Given this list of marker genes Ank3, Bok, Parp1, Cnga2, Trpm4, Chrna1, Rbfox2, Scn8a, Nedd4l, Ppif, Park7, Myoc, Scn1b, Scn2b, Smad7, Slc6a4, Atp5if1, Ywhah, Gja1, Ptpn3, Chrna5, Kcnh2, Chrne, Scn5a (NCBI Gene Id 20271), Rack1, Ntsr1, Chrna6, Gclc, Gclm, Chrna4, Scn2a, Scn1a (NCBI Gene Id 227987), Best2, Cacna1d, Chrnb4, Cacna1i, Hcn2, Jun, Kmt2a, Scn4a, Cacna1g, Chrnb3, Hcn3, Scn11a, Adcy10, Chrnd, Cacna1a, Got1, Atp1a2, Cacna2d1, Dcn, Slmap, Grik1, Col6a1, Gpd1l, Chrna3, Ngfr, Kdr, Chrnb1, Oga, Cnga1 (cyclic nucleotide gated channel alpha 1), Scn10a, Clcn2, Cacna1c, Hcn1, Chrng, Casp1, Alb, Scn3b, Phox2b (NCBI Gene Id 245706), Scn3a, Tspo (translocator protein), Hsh2d, Cacna1h, Chrna2, Prkcz, Npff, Cacng2, Chrnb2, Creb1, Shtn1, Cav3, Cav1, Mllt11, Abcd1, P2rx7, Fgf12, B2m, Scn9a, Cdkn2a, Fhl1, Alox12, Tbx5, P2rx4, Kcnq2, Hcn4, Fzd9, Camk2d, Edn1, Lrrk2, Adora2a, Gja5, Kcnq3, Ppp2r3c, Cacnb2, Cck, Src, Asic3, Scn4b, Atp1a3, Cftr, Rangrf, here is a description of the gene set: studied in species Mus musculus The process in which membrane potential decreases with respect to its steady-state potential, usually from negative potential to a more positive potential. For example, the initial depolarization during the rising phase of an action potential is in the direction from the negative steady-state resting potential towards the positive membrane potential that will be the peak of the action potential. Mouse Gene Set: GOBP_MEMBRANE_DEPOLARIZATION